Given this list of marker genes H2-Eb2, Socs6, Itgal, Alcam, Card11, Cd37 (NCBI Gene Id 12493), Nptn, Cd53, Lgals3, Cd3e, Cd28, Pdcd6ip, Cd6, Coro1a (NCBI Gene Id 16902), Icam1, Carmil2, Prkar1a, Fyb2, H2-Ea, Scimp, Rhoh, Stoml2, Cracr2a, Arhgdia, Dusp3 (dual specificity phosphatase 3 (vaccinia virus phosphatase VH1-related)), H2-Eb1, Bcl10, Dlg1 (discs large MAGUK scaffold protein 1), Zap70, Il4i1, Myh9, Prkcq, Nedd9, Card10, Lat, Ezr, Trbv26 (NCBI Gene Id 21596), Atp2b1, Crtam, Cd81, Vav3 (NCBI Gene Id 99531), Calhm6, Scrib, Lck, Skap1 (src family associated phosphoprotein 1), Snx27, Prf1, Stx7 (NCBI Gene Id 53331), Havcr2, Ptprj, here is a description of the gene set: An area of close contact between a lymphocyte (T-, B-, or natural killer cell) and a target cell formed through the clustering of particular signaling and adhesion molecules and their associated membrane rafts on both the lymphocyte and the target cell and facilitating activation of the lymphocyte, transfer of membrane from the target cell to the lymphocyte, and in some situations killing of the target cell through release of secretory granules and/or death-pathway ligand-receptor interaction. Mouse Gene Set: GOCC_IMMUNOLOGICAL_SYNAPSE species: Mus musculus